The following is a description of a gene set: Human Gene Set: GOBP_TRNA_THREONYLCARBAMOYLADENOSINE_MODIFICATION The attachment of a carbonyl group and a threonine to the amino group of the adenine residue immediately 3' of the anticodon, in tRNAs that decode ANN codons (where N is any base). studied in species Homo sapiens, and this is the list of marker genes: GON7, TPRKB, YRDC, OSGEP, OSGEPL1